The following is a description of a gene set: Any process that activates or increases the frequency, rate or extent of the covalent alteration of one or more amino acid residues within a protein. Human Gene Set: GOBP_POSITIVE_REGULATION_OF_PROTEIN_MODIFICATION_PROCESS species: Homo sapiens, and this is the list of marker genes: XBP1, ARAF, UBQLN1 (NCBI Gene Id 54347, ubiquilin 1), RACK1, TAB2, JTB, IL18, TNFRSF10A, CD74, PIH1D1, MRNIP, TLR3, S1PR2, TNFSF18, WNT5A, ANGPT1, DCUN1D2, CLIP3, FBN1, DYNAP, CDKN2A, CDKN1A, PPIA, BIRC3, MAP2K2, PIBF1, CENPS, MUL1, UBA2, IL34, STUB1, DERL1, SASH1, PRLR, PELI2, NIBAN1, ENPP2, XRCC5, AKTIP, ARL2BP, DOK7, THPO, KNDC1, KDR, CEP295, KAT5, PLK1, CD80, TXN, DCUN1D3, CAV1, SPRY2, PIAS3, SYAP1, TNFRSF18, SIRT1, PAXIP1, EFNA5 (NCBI Gene Id 1946), PARP9, DIPK2A, RARRES2, LEP, EGR1, PDGFA, ARRDC4, DIP2B, COMMD1, LTF, EFNA1, NRG1, RSPO1 (NCBI Gene Id 284654), TENM1, UBE2D1, NDFIP1, FZR1, LIMCH1, HDAC4, WBP1L, PINK1, NHLRC1, EGFR, ERCC6, WDFY2, ARHGEF2, BIRC2, SENP2, GSK3B, RCHY1, IL21, TICAM1, RAMP1, OSM, TRIM6, ADCYAP1, ERBB4, NNMT, RNF180, DDR2, TLR6, PIK3C3, PIK3CG, ITGB1BP1, AIMP2 (NCBI Gene Id 7965), MT3, CAB39, GSK3A, ERN1, BCL10, ARRB1, DCUN1D5, MAGEC2, CBLB (Cbl proto-oncogene B), CCNY, ZFP91, CSPG4, MAPK1, BRAF, VCP, PHF23 (NCBI Gene Id 79142), TBC1D7, SAE1, KLHL40, UBE3A, XIAP, PTPRC (NCBI Gene Id 5788), SKP1 (S-phase kinase associated protein 1), STK4, PIK3R6, STRADB, ETAA1, TGFB1, UBE2C, WFS1, PIK3R5, RASSF5, GABARAP, MMP9, NPM1, CAMK1, MAP3K11, SLC51B, TNF (NCBI Gene Id 7124), NDFIP2, TNK2, FLOT1, MARCHF7, PDGFB, LACRT, RIPK3, TRAF4, TRAF6, CDK2AP1, LCP2, UBE2V2, ELANE, ASPSCR1, MTA1, CUL3, FGF19, MAGEA2, PDGFRB, CSF1R, PDCD10, HSPA5, IL31RA, IL11, PROM2, PTK2B, FGF10, CNTF, FGFR1, IGF1, LILRA5 (leukocyte immunoglobulin like receptor A5), IL12A, DIRAS1, RAPGEF2, TNIP1, AGAP2, MST1R, JAK2, FGF1 (fibroblast growth factor 1), ODAM, CENPE, MAP3K4, RNF111, ARNT (aryl hydrocarbon receptor nuclear translocator), SRC, FAM107A, HDAC3, CRIPTO, PEF1, CHP1, FANCM, FAM20A, NEDD9, HAMP, MMD2, RASSF2, FGF2 (fibroblast growth factor 2), FLT3, PRKCD, BRMS1, THBS4, FAM161A, EREG, HSPBP1, IL6, CARD14, TCIM, DDX3X (DEAD-box helicase 3 X-linked), RPS2, NOP53, TPX2, GPER1, FBH1, ERBB2, STRADA, BMAL1, PFN2, PIM1, PIAS4, AKT1, TRAF2, BMP2, CALCA, BIRC7, ECT2, DDRGK1, FGF18, PARP14, UBE2S, MAGEA2B, GOLGA2, ARRDC3, PTPN22, ADCY8, TNFSF15, RHOA, MUSK, FBXW7, EGF, UBB, PIN1, MAP3K10, ROCK2, IFNG, WNK3, CREBL2, NGF, IFNL1, MAP4K2, DNAJB2, TSPYL5, NOD2, STK11, SRCIN1, TNIK, HUWE1, UBE2V1, RAB3GAP1, ATG14, SEPTIN4, CLSPN, RAF1, KDM1A, DCUN1D4, CD4, UNC119, LAPTM5, KIF14, INAVA, TRIB3, MAPK9, ANGPT4, RASSF1, CRY1, DRD4, VEGFB, RIPK1, HES1, UBE2N, COPS8, FANCI (NCBI Gene Id 751608), MAP3K7, ZC3H12A, PSMD10, NEK10, VEGFA, FGFR3, SNX9, LRRK2, CENPX, DNAJA3, UBE2K, BMI1, XRCC6, SVIP, EZH2, NMI, TOLLIP, FLT1, CACUL1, S100A12, MYDGF, AMER1, FBXO4, STOX1, ITLN1, NSMCE3, RASGRP1, RALBP1, MALT1, NPTN, CDC20, CHI3L1, TAOK3, RAP2A, CARD10, PTTG1IP, CEMIP, CTF1, TBX1, ABL1, CHFR, MAP3K5, BIRC8, HMGA2, PELI1, SKP2, ARHGEF5, BANK1, BTRC, ADIPOQ, RBX1, KIT, RASD2 (RASD family member 2), CNOT9, DIRAS2, ATG7, LIF, GNL3, UBE2L3, TNFRSF10B, MAP2K1, IL15, DCUN1D1, FAXDC2, PIAS1, SEMA4D, ACVR2A, FGF7, PTK2, PRICKLE1, ALS2, ABI1, TOM1L1, LAT, PTPN1, MAD2L2, TPD52L1, SPHK1, DIP2A, RAC1, RAB3GAP2, IL20, MMD, RIPK2, CDK5RAP3, BMP4, SPDYA, FLT4, AXIN1, BRAT1 (BRCA1 associated ATM activator 1, NCBI Gene Id 221927), GPRC5B, FBXO33, GAS6, CDC14B, SPSB4, MAP2K3, SPRTN, ADAM17, CCDC88A, PILRB, RALB, CIB1, CASS4 (Cas scaffold protein family member 4), PDCD6, HLA-DRB1, C3, ZNF268, RWDD3, IRGM, PRKN, TANK, RAP1A, PLAUR, MYCBP2